The following is a description of a gene set: studied in species Homo sapiens Any process that activates or increases the frequency, rate or extent of amyloid precursor protein catabolic process. Human Gene Set: GOBP_POSITIVE_REGULATION_OF_AMYLOID_PRECURSOR_PROTEIN_CATABOLIC_PROCESS, and this is the list of marker genes: GSAP, AGER, RELA, GSK3A, EFNA3, ROCK2, ABCA2, MIR206, SPON1, LRRTM3, IFNGR1, TNF, ABCG1, CHRNA7, CASP3, IFNG, RANBP9, LYN, SP1, APOE, SLC2A13, PICALM, CSNK1E (casein kinase 1 epsilon), EFNA1, EPHA4, APP (NCBI Gene Id 351), CLU